The following is a description of a gene set: The aggregation, arrangement and bonding together of a set of components to form an extracellular vesicular exosome, a membrane-bounded vesicle that is released into the extracellular region by fusion of the limiting endosomal membrane of a multivesicular body with the plasma membrane. Exosomes are defined by their size, which generally ranges from 30 nm to 100 nm. Human Gene Set: GOBP_EXTRACELLULAR_EXOSOME_ASSEMBLY studied in species Homo sapiens, and this is the list of marker genes: SDC1, SDC4, PDCD6IP, CD34, TSG101, SDCBP, STAM